The following is a description of a gene set: Human Gene Set: HP_ABNORMAL_AORTIC_VALVE_MORPHOLOGY studied in species Homo sapiens Abnormal aortic valve morphology Any abnormality of the aortic valve., and this is the list of marker genes: TNXB, NXN, MYH11, ZMYM3, FANCE, GBA1, TMEM70, PUF60, SEMA3E, MCTP2, FBN1, PPM1D, ACTB, ZEB2, COMT, BRAF, FDFT1, ADAMTS19, FANCB, AGO2, SRY, FANCG, MMP2, ABCC9, MMP14, NADSYN1, FANCC, MAT2A, BCAS3, TMEM270, B3GALT6, PPP1R13L, KMT2D, NFE2L2, B3GAT3, STX1A, HLA-B, SLX4, FANCD2, RIGI, MYH3, H3-3B, MFAP5, GTF2IRD1, H3-3A, ACTA2, MYLK, BAZ1B, JMJD1C, UBE2T, DPF2, WAC, SMAD6, GJA8, NCF1, SKIC3, KIF3B, TAF2, SH2B1, TRAF7, MLXIPL, ROBO4, BBS2, MYH7, METTL27, CREBBP, BCOR, KCNE5, NOTCH1, ADA2, CAPN15, CHD7, IFT122, VPS37D, PRKG1, SGO1, TGFBR2, MMP21, BRIP1, TBX1, HIRA, TGFBR1, RAD51, RPL26, TBL2, NOTCH3, SKIC2, FANCI, EP300, SMAD2, SEC24C, PALB2, FOXF1, LRPPRC, DNAJC30 (NCBI Gene Id 84277), GATA5, GP1BB, CCNQ, ARVCF, PACS1, PPP2R5D, GLA, ZNF462, WT1, FKBP6, KANSL1, BUD23, HEY2, NAA10, GATA6, YY1AP1, XYLT2, ARHGAP31, BRCA2, TGFB2, MAP3K7, CHST3, LOX, DOHH, RREB1 (ras responsive element binding protein 1), RAC1, ARSK, SMAD4, SKI (SKI proto-oncogene), THSD4, RFC2, SNIP1, ACSL4, FLNA, NFIX, IFIH1, EIF4H, FOXE3, NKX2-5, ELN, NIPBL, MLX, FANCL, TGFB3, AMMECR1, RAD51C, SMC3, EDNRA, FANCA, HGD, UFD1, CLIP2, BRCA1, GJA5, SCAF4, LZTR1, FANCF, FANCM, SLC25A24, RFWD3, CHRNG, MAP2K2, RAI1, XRCC2, RAP1B, ERCC4, LIMK1, KDM6A, GTF2I, RPS6KA3, TAB2, LMNA, MAD2L2, CBL, ZFX, IL12B, PLCH1, OGT, GTF2IRD2, ZMPSTE24, GNPTAB, POLR1A, SMAD3 (NCBI Gene Id 51521), MYOCD, FBN2, HNRNPK, SPTBN1